The following is a description of a gene set: species: Homo sapiens Genes up-regulated in natural T reg with non-functional FOXP3 versus T conv. The gene expression profile of peripheral Foxp3+ natural regulatory T cells isolated from Foxp3/EGFP bicistronic mice was compared to that of in vitro-induced regulatory T cells and to CD4+ conventional (Foxp3-) T cells. The role of the regulatory T cell transcription factor Foxp3 in shaping the transcriptosomes of natural and induced regulatory T cells was analyzed using mice expressing a mutant FOXP3-EGFP fusion protein (Foxp3deltaEGFP). We used gene expression microarrays to examine the transcriptional programs of natural and induced regulatory T cells and the function of Foxp3 in organizing the transcriptosomes of the respective cell type from publication Haribhai D, Lin W, Edwards B, Ziegelbauer J, Salzman NH, Carlson MR, Li SH, Simpson PM, Chatila TA, Williams CB (PMID 19265124) Human Gene Set: GSE14415_FOXP3_KO_NATURAL_TREG_VS_TCONV_UP, and this is the list of marker genes: AMPD1, ABTB3, PATJ, AP1AR, CRLF3, ACYP1, KCNMB3, HSPBAP1, CRIPTO, CAMSAP2, BDP1, IL7R, RIMOC1, TDRKH, TLR1, RPLP2, SESN3, OMP, PLEKHA1, PALS1, ID3, TCF20, CALCRL, TENT5A, RRAS2, RAD50, MYC, MGST2, PSD3, SELL, SCML4, PARP8, SHF, SLC6A19, F2RL1, SH3BP5, USP28, ARL4C, DNAJC7, ZNRF1, NPEPL1, NEGR1, TET1, KRBA1, AKT3, SPACA1, ICE2, LEF1, ARHGAP15, TGFBR3, PNPLA7, CCR9, RAPGEF6, BPTF (NCBI Gene Id 348241), ALDH3B2, SKI, BRWD1, GPATCH4 (G-patch domain containing 4 (gene/pseudogene)), EPHX1, TCF7 (transcription factor 7), EHMT1, GRIA3, PDK1, CACNA1G, IFRD2, SESN1, HNRNPH3, SLC49A4, N4BP2, SELE, CARD6, EVL, JPH3, DISP2, RUFY2, PAG1, SSH2, ADGRL2, PLEKHM1, KRTAP17-1, RALGPS2, LRRC1 (leucine rich repeat containing 1), NDUFAF4, RGS10, CARNS1, TTC3, METTL8, TRAT1, AKAP8L, ARID4A, BAZ2B, PDCD4, NEDD4L, SLC43A2, RPS29, SH3PXD2A, ITGAE, IPCEF1, CNGA1, CHD2, POLR3D, POLR1G, KDM5B, AFP, ABCA1, RAB3IP, NIPBL, ADCY6, OXT, ABCG1, ZMYM2, L3MBTL1, KLF3, SI, MGA, CREBL2, DCAF6, PHF21A, BCLAF1, BICRA, TOP2B, TBXA2R, DDC, LRRC23, EIF4A2, APPL2, PCM1, SLC12A7, LDHB (NCBI Gene Id 3945), PNRC1, ELMO3 (engulfment and cell motility 3), ARID1A, TMIE, UTP25, TREML2 (NCBI Gene Id 79865), RAPGEF4, FAM78A, PRPF38B, LRRC4B, EIF5, FBXL14, SELENOP, PNPO, TASOR2, INPP4B, CEP68, CHST15, DPH5, INHBB, IFNGR2, STAMBPL1, MON2 (NCBI Gene Id 23041), PELI1, SNX29, POLR1A, ELP3, SSBP2, XKRX, GALP (galanin like peptide), BCOR, PRP4K, RNF167, ADGRG5, DZIP1, WDR13, CD2AP, PPRC1, PAN3, PRSS12, NSG2, RPL36